The following is a description of a gene set: from publication Chen Y, Wang X (PMID 31504780) studied in species Homo sapiens Genes predicted to be targets of miRBase v22 microRNA hsa-miR-758-3p in miRDB v6.0 with MirTarget v4 prediction scores > 80 (high confidence targets). Human Gene Set: MIR758_3P, and this is the list of marker genes: FBN1, RAD52, ZNF226, PDZD7, ZNF618, FBRSL1, ZNF257, RBM15B, PPID, FUT9, CNNM4, ZNF385C (zinc finger protein 385C), RORA, VEZF1, PRKAR2B, WWP2, MEPE, PRRG1, SUN2, BACH2, KPNA3, PCDHB13, USH2A, BMP7, AFG1L, WTAP, ZMYM2, APLF, WWC2, NTM, ST6GAL2, GRIK3, NHLRC3, ZNF611 (NCBI Gene Id 81856), DGKH, PRR27, TCFL5, ENTPD1, VAPB, SUCNR1 (NCBI Gene Id 56670), MIPOL1, CEP15, CHFR, NOP2, KDM6A, RNF114, RNF113B, SLC25A16, CARF, ZFHX3, ACLY, ZNF808, ZBTB7A, HRH4, PCBD2, TRIP11, EEA1, ZDBF2, SGIP1, SMIM9, WDR20, MEIS2 (NCBI Gene Id 56908), HSD17B13, SEC62, SRGAP1, ZNF432 (zinc finger protein 432), STK40, LIN7A, MTHFD2, PUM2, NRG1, DGKE, FLVCR1, SLMAP, PLP2, PAPSS2 (NCBI Gene Id 9060), TBX4, ADAMTS17, RIOX1, PARP12, CCDC43, SRP68, C2CD2, PPP2R1B, TADA2B, KLF9, B3GNT9, NAA40, SMLR1, CDC42BPA, SLC24A2, GCSH, ZNF761, ZNF503, MCAT, ADD1, RASA3, ENPP3, ZNF28, MAP2K1, HIPK3, TCEAL7, COLGALT1, UNC5D, PGRMC1, TYRO3, HAUS2, COMMD2, ANKH, COPG2, MAP4K3, TKTL2, GAD2, ZNF250, C5orf15, MOB3B, PALM2AKAP2, ZBTB18, FYB2, SLC6A14, EXOC6, MIA3, LRFN2, SOCS7, CYP7B1, C1orf198 (NCBI Gene Id 84886)